Given this list of marker genes COX7A1, COX8A, COX7A2, COX6A1, COX6C, COX5A, COX4I1, COX5B, COX7C, SURF1, COX7B, COX6B1, here is a description of the gene set: Human Gene Set: MODULE_103 Genes in the cancer module 103. studied in species Homo sapiens